The following is a description of a gene set: from publication Fu W, Ergun A, Lu T, Hill JA, Haxhinasto S, Fassett MS, Gazit R, Adoro S, Glimcher L, Chan S, Kastner P, Rossi D, Collins JJ, Mathis D, Benoist C (PMID 22961053) Human Gene Set: GSE40274_CTRL_VS_FOXP3_AND_XBP1_TRANSDUCED_ACTIVATED_CD4_TCELL_UP The transcription factor FoxP3 partakes dominantly in the specification and function of FoxP3+ CD4+ T regulatory cells (Tregs), but is neither strictly necessary nor sufficient to determine the characteristic Treg transcriptional signature. Computational network inference and experimental testing assessed the contribution of several other transcription factors (TFs). Enforced expression of Helios or Xbp1 elicited specific signatures, but Eos, Irf4, Satb1, Lef1 and Gata1 elicited exactly the same outcome, synergizing with FoxP3 to activate most of the Treg signature, including key TFs, and enhancing FoxP3 occupancy at its genomic targets. Conversely, the Treg signature was robust to inactivation of any single cofactor. A redundant genetic switch thus locks-in the Treg phenotype, a model which accounts for several aspects of Treg physiology, differentiation and stability. Genes up-regulated in CD4 T conv: control versus over-expression of XBP1 and FOXP3. species: Homo sapiens, and this is the list of marker genes: SCLT1, STIP1, CELA3B, CENPM, CASP4, ACACA, PYCR1, WHRN, KCNC3, PGP, CHPF, MIR17HG, NOB1, CRTAM, ZBTB8A, SNHG1, MRI1, ERH, RANBP1, PBK, NUP205, KLF12, ZHX3, MYO19, PMEPA1, SLC5A3, SNAPC4, PDZK1IP1, NSMCE2, RSRC2, UTP4, MIRLET7D, STMN1, CCND2, ESPL1 (extra spindle pole bodies like 1, separase), LETM1, E2F4, SUCLA2, OMG, SLC5A6, CPLX3, LSM4, RARS2, VAC14, MYBBP1A, JCHAIN, LINGO2, H4C4, YWHAE, PDXP (NCBI Gene Id 57041), MFSD2A, TNFSF9, USP2, HYOU1, PFKP, RBMX2, SNRPD3, AXL, PPRC1, EXO1, HPDL, LRR1, ANO7, RPS19BP1, MIR96, ADCY8, EXOSC7, RAB11FIP4, TCAF1, RASD2, ABHD13, TNFRSF19, CCNB2, TXN2, DOT1L (NCBI Gene Id 84444), H1-5, LAP3, RTEL1, AHSA1, SLC35B1, RRP9, CCDC87 (NCBI Gene Id 55231), GPR183, XYLB, DBI, NUBP2, HSPA9, NRF1, SSRP1, RAB18, CSF1, RRP12, SINHCAF, CDCA5, HNRNPH2, CCNF, CCNH, DNPH1, TLE3, CDC20, C1QBP, PDAP1, FASN, H1-1, OAS3, SLC25A43, CAVIN4, PDSS1, TMEM14C, THOP1, PAICS, AGPAT5, RAD54L, NUDC, AHCY, POLR2L, PVT1, SMN1, MCM2, ZFPM2, NME1, NOL9, ZC2HC1C, PRIM1, HSPD1, DPP7, TNFRSF4, ACOT7, CACNA1E, MKI67, ANKLE1, DDX31, TGM4, KRT5, WNK1, PAF1, NEFH, NOP10, DCTPP1, HCFC1, POLD1, PPP5C, ELAC2, NCAPH, RAD50 (RAD50 double strand break repair protein), CTSLP3, BATF, DMBX1, RAB17, EME1, ATXN1, MAFK, ASIC2, WDR4, PCDHB16, NOP56, LTA, SLC39A7, NCAPG2, MRPL55, PUSL1, SLC12A4, URB2, CDCA2, IPO5, BYSL, SPRED2